Given this list of marker genes Myh14, Scn11a, P2rx4, Ffar3, Gm2990, Gsg1l, Pafah1b1 (NCBI Gene Id 94322), Chrna7, Grik2, Dpp6, Bbs10, Chrna5, Fmr1, Pawr, Nfasc, Mag, Slco1b2, Chrna4, Pmp22, P2rx2, Dcdc2a, Scn9a, Kcnmb2, Oprm1 (opioid receptor, mu 1), Jam3, Otoa, Scn8a, Scn3a, Prx, Il6, Cacng2 (NCBI Gene Id 77978), Ghrl, Nrcam, Scn1a, Cntnap1, Rgs21, Dmrt3 (doublesex and mab-3 related transcription factor 3), Hcn1, Agt, Atp1a3, Cntnap2, Scn5a, Kcnmb3, Avpr1a, Sod1, Cacnb4, Cacng3, Cldn19, Gria1, Kcnmb4, Ank3, Clcn1, Scn1b, Chrna1, Gprin3, Tymp, Ntrk3, Ntrk2, Cacng5, Pak1, Kcnk2, Itga2, Plec, Avp, Chrnb4 (cholinergic receptor, nicotinic, beta polypeptide 4), P2rx7, Kcnk4, Cacna1e, Kcnq2, Cacna1i, Atp1a2, Sptbn4, Penk, Fgf12, Scn4a, Efr3b, Rapgef4, Glra1, Kcna2, Kcnq3 (potassium voltage-gated channel, subfamily Q, member 3), Gjd2, Cacng4, Cacna1a, Trpa1, Tnr, Kcna1, Kcnd2, Drd1, Ghsr, Scn4b, Cacng7, Gpr35, Npr2, Gba1, Hcrt, Grm7, Drd5, Scn10a, Chrnb2, Mtnr1b, Col6a1, Fkbp1b, Gper1, Kcnc4, Ifng, Cartpt, Scn2a, Cstl1, Asic5, P2rx1, Kcnj8, Kcnma1, Gpr88, Chrm5, P2rx3, Cacng8, S1pr1, Mtor, here is a description of the gene set: species: Mus musculus Mouse Gene Set: GOBP_TRANSMISSION_OF_NERVE_IMPULSE The neurological system process in which a signal is transmitted through the nervous system by a combination of action potential propagation and synaptic transmission.